The following is a description of a gene set: Mouse Gene Set: chr9B species: Mus musculus, and this is the list of marker genes: Pml, Gm17853, Ppcdc, Ccdc33, 1600029O15Rik, Gm7616, Fem1b, Gm24526, Gm26868, Uaca, Ireb2, Gm7653, Gm10658, Cox5a, Cimap1c, 1700036A12Rik, Myo9a, Sema7a, Nrg4, Arid3b, Gm33180, Pstpip1, Arih1, Csk, Imp3, Gm7439, Gm18996, Islr, Gm33699, Gm39348 (predicted gene, 39348), Gm33053, Neil1, Cln6, Senp8, Chrna3, AY074887 (NCBI Gene Id 246735), Neo1 (neogenin), Paqr5, Ulk3, Gm34004, 4930563M21Rik, Man2c1os, Gm17322, Gm6166, Rcn2, Stoml1, Gm22099, Glce, Gm10657, Isl2, Ptpn9 (NCBI Gene Id 56294), Spesp1, Kif23, Tbc1d21, Sin3a, Trcg1, Skor1, 1700041C23Rik, Gm24641, Ubl7, Gm10653, Tmem266, D9Wsu149, Cplx3, Gm7395, Cd276, Adpgk, Gm5121, Gm26631, Nptn, Snx33, Scamp2, Insyn1 (inhibitory synaptic factor 1), Gramd2a, Lrrc49, Scamp5, Gm33914, Coro2b, Gm34105 (NCBI Gene Id 102637237), Man2c1, Hykk, Gm19208, Cspg4, Gm7589, Etfa, Anp32a, Psma4, Gm18103, Rps11-ps1, Clk3, 1700017B05Rik, Calml4, Mir6385, Gm2735, Gm16130, Gm6082, B930092H01Rik, Hcn4, Cyp1a2, Fam219b, Gm20620, Gm19936, Larp6 (NCBI Gene Id 67557), Ube2q2, Gm34424, Fbxo22, Bbs4, Islr2, Chrnb4, Edc3, Lman1l, Btf3-ps2, Rplp1, Peak1os, Gm15625, Lingo1 (leucine rich repeat and Ig domain containing 1), Tspan3, Gm5917, Chrna5 (cholinergic receptor, nicotinic, alpha polypeptide 5), Itga11, Stra6 (stimulated by retinoic acid gene 6), Gm20275, Tmem202 (NCBI Gene Id 73893), Cyp11a1, Gm7435, 2010001M07Rik, Nr2e3, Parp6 (NCBI Gene Id 77523), A730043L09Rik, Gm34322, Celf6, Pkm, Gm35288, Gm5122, Rec114, 4930461G14Rik, Snupn, Scaper (NCBI Gene Id 78726), Gm9869, Rpp25, Mir5133, Gm10655, Hmg20a (NCBI Gene Id 75713), Ube2srt, 4930442G15Rik, Commd4, 9230112J17Rik, Mpi, Peak1, Tle3, Pias1, 1700072B07Rik, Hexa, Thsd4, Loxl1, Cyp1a1, Gm7444, Gm23407